The following is a description of a gene set: A reproductive process occurring in the mother that results in birth. Human Gene Set: GOBP_MATERNAL_PROCESS_INVOLVED_IN_PARTURITION studied in species Homo sapiens, and this is the list of marker genes: CYP1A1, OXTR, LDOC1, NODAL, EDN1